The following is a description of a gene set: Candidate genes in genomic amplification regions in hepatocellular carcinoma (HCC) samples. Human Gene Set: MIDORIKAWA_AMPLIFIED_IN_LIVER_CANCER studied in species Homo sapiens Genomic amplification of oncogenes and inactivation of suppressor genes are critical in the pathogenesis of human cancer. To identify chromosomal alterations associated with hepatocarcinogenesis, we performed allelic gene dosage analysis on 36 hepatocellular carcinomas (HCCs). Data from high-density single-nucleotide polymorphism arrays were analysed using the Genome Imbalance Map (GIM) algorithm, which simultaneously detects DNA copy number alterations and loss of heterozygosity (LOH) events. Genome Imbalance Map analysis identified allelic imbalance regions, including uniparental disomy, and predicted the coexistence of a heterozygous population of cancer cells. We observed that gains of 1q, 5p, 5q, 6p, 7q, 8q, 17q and 20q, and LOH of 1p, 4q, 6q, 8p, 10q, 13q, 16p, 16q and 17p were significantly associated with HCC. On 6q24-25, which contains imprinting gene clusters, we observed reduced levels of PLAGL1 expression owing to loss of the unmethylated allele. Finally, we integrated the copy number data with gene expression intensity, and found that genome dosage is correlated with alteration in gene expression. These observations indicated that high-resolution GIM analysis can accurately determine the localizations of genomic regions with allelic imbalance, and when integrated with epigenetic information, a mechanistic basis for inactivation of a tumor suppressor gene in HCC was elucidated. from publication Midorikawa Y, Yamamoto S, Ishikawa S, Kamimura N, Igarashi H, Sugimura H, Makuuchi M, Aburatani H (PMID 16785998), and this is the list of marker genes: WNT2, PIP4K2B, HNF1B, ARHGAP23, DUSP14, SYNRG, CAV2, LRRC37A11P, SNRNP48, PCGF2 (NCBI Gene Id 7703), LASP1, CAPZA2, CTTNBP2, PSMB3, PRCP, C17orf78, SOCS7, DDX52, ANKRD7, CFTR, MET, CACNB1, CWC25, DDIAS, RREB1, CCNY, ASZ1, CCN1, FBXL20, DSP, RPL19, PLXDC1 (NCBI Gene Id 57125), RDM1P5, ACACA, CUL2, TBC1D3B, GJD4, MRPL45, PARD3, SRCIN1 (SRC kinase signaling inhibitor 1), MTRR, FZD8, ADCY2, FAM181B, RIOK1, CREM, TADA2A, CAGE1, ST7, RPL23, CAV1, MLLT6, FASTKD3, SSR1, LSM8